The following is a description of a gene set: Human Gene Set: PID_AVB3_INTEGRIN_PATHWAY studied in species Homo sapiens Integrins in angiogenesis from publication Schaefer CF, Anthony K, Krupa S, Buchoff J, Day M, Hannay T, Buetow KH (PMID 18832364), and this is the list of marker genes: ILK, PI4KB, TLN1, PIK3R1, COL9A2, RAC1, EDIL3, COL6A1, CDKN1B, COL9A1, VAV3, ROCK1, COL14A1 (collagen type XIV alpha 1 chain), COL9A3, COL11A2, COL4A5 (NCBI Gene Id 1287), COL7A1, PIK3C2A, VCL, COL1A1, ITGB3, SDC1, VTN, RPS6KB1, PI4KA (NCBI Gene Id 5297), ANGPTL3, RHOA, COL4A6, F11R, VEGFA, COL8A2, COL5A1, COL17A1 (collagen type XVII alpha 1 chain), SRC, COL1A2, AKT1, ITGAV, ADGRA2, COL6A2, COL11A1, SPP1, TGFBR2, HSP90AA1, CASP8, FGF2, MAPK3, CSF1, COL16A1, COL2A1, MAPK1, IRS1, CBL, CSF1R, IGF1R, BCAR1, COL3A1, FN1, PIK3CA, COL12A1, COL6A3, COL10A1, PXN, COL8A1, COL4A1, COL15A1, COL4A4, PTK2, COL5A2, KDR, COL13A1, COL4A3, PTPN11, PTK2B, MFGE8